Given this list of marker genes LIPG, MIR96, APOA2, APOM, MIR223, APOE, MIR185 (NCBI Gene Id 406961), MIR144, APOC2, APOA1, MIR302A, GPLD1, MIR33A (microRNA 33a), SCARB1, MIR33B, LDLR, APOC3, TREM2, here is a description of the gene set: Human Gene Set: GOBP_HIGH_DENSITY_LIPOPROTEIN_PARTICLE_CLEARANCE The process in which a high-density lipoprotein particle is removed from the blood via receptor-mediated endocytosis and its constituent parts degraded. studied in species Homo sapiens